Given this list of marker genes APPL1, CITED1, RBP4, GSTP1, CD2AP, KCNJ8, SRSF6, GSK3A, LPIN2, PAK1, PDK2, ECHDC3, CEACAM1, SOS1, KHK, SGCB, CAT, ZDHHC7, NCL, RPS6, PLN (phospholamban), IGF1R, AHSG, MEAK7, MYO1C, ERFE (NCBI Gene Id 151176), EIF6, IL1B, HRAS, MAPK3, WDTC1, PRKDC, PRLH, BCAR1, BGLAP, PIK3C2A, SOS2, FOXO1, INSIG1, GCK, ABCC8, KLF15, TNS2, POU4F2, PRKCI, SRD5A1, SLC25A33, INHBB, CPEB1, GRB14, SMARCC1, SNX5 (sorting nexin 5), LEP, NDEL1, ADIPOQ, PIK3R1, SLC27A1 (solute carrier family 27 member 1), RBX1, RELA, NR1H4, XBP1, KANK1, RAB8A, CRY2, PIK3R3, FER, SESN2, PKM, PDK4, ZNF592, RARRES2, CFLAR, FOXO4, SREBF1, HADH, SELENOS, SLC27A4, C2CD5, SIK2, TRARG1, OTC, PRKCB, MAPK14, GRB2, FABP3, OTOP1, PRKCZ, ATP2B1, SOCS1, SOCS3, RPS6KB2, YWHAG, GCNT1, STXBP4, LONP1, TRPV4, INSIG2, RAB31, CELA2A, FBP1, BCAR3, AP3S1, AKT2, USF1, ZNF106, PCSK9, SIRT1, MAPKAP1, SORL1, STXBP3, NPPA, PHIP, GPR21, CRY1, GPLD1, PTPN11, SORT1, SESN3, TBC1D4, EIF4EBP2, NUCKS1, UCP3, GSK3B, RAB13, IGF2, VAMP2, ZBED3, RAF1, EEF2K, SP7, PID1, KCNQ1, CTSD, PRKCD, GHRHR, TRIB3, HSD11B2, PIP4K2C, PLA2G1B, CAD, INS, RETN, GCLC, SORBS1, SRSF5, MIR195, ACVR1C, MIR15B, GHR, CSRP3, ADIPOR1, NAMPT, CUL3, UCP2, INPPL1, LYN, FFAR3, PRKAA1, MYO5A, GAL, NCOA1, MSTN, COL1A1, APC, MIR1271, IRS2, RHOQ, FBXW8, AGRP, CUL7, IDE, PCK1, SLC39A14, PNPLA3, SLC2A1, MAPK1, VGF, SLC2A4, PIK3R2, HADHA, EPRS1, TNFRSF11A, KBTBD2, SLC2A8, USO1, ALAS1, RB1, TRIM72, BAIAP2, ALPL, GHSR, SP1, ENPP1, IGFBP1, FUT7, TSC2, KAT2B, SLC22A12, RBM4, HDAC5, IGF1, EPM2AIP1 (NCBI Gene Id 9852), SHC1, PPARG, CAV2, MC4R, PTPRJ, CPEB2, GOT1, RAB10, TSC1, INPP5K, MIR107, PIP4K2A, PIK3CA, PKLR, IRS1, GKAP1, IL10, EGR1, PTPN1, C1QTNF12, MTCL2, OPRK1, AKT1, VPS13C, INSR, ERRFI1, GPR82 (NCBI Gene Id 27197), GALP, PPARA, MIR103A1, UPRT, RPS6KB1, SH2B2, NCK1, HMGCS2, FOS, HDAC9, VWA2, SLC9A1, GRB7 (growth factor receptor bound protein 7), SYAP1 (synapse associated protein 1), APPL2, INSRR, PDPK1, LPIN3, DENND4C, NCOA5, COL6A1 (NCBI Gene Id 1291), MIR379, SERPINA12, SOCS7, ZBTB7B, PRKCQ (NCBI Gene Id 5588), GAB1, MZB1 (NCBI Gene Id 51237), DNAI1, FOXC2, AANAT, IRS4, LPIN1, STAT1, PDE3B, OGT (O-linked N-acetylglucosamine (GlcNAc) transferase), PTPN2, PIP4K2B, CAPN10, SCAP, SRSF4, PARP1, PCK2, OSBPL8, G6PC1, NCOA2, ZFP36L1, GRB10, BLVRB, MTOR, PTPRE, here is a description of the gene set: studied in species Homo sapiens Any process that results in a change in state or activity of a cell or an organism (in terms of movement, secretion, enzyme production, gene expression, etc.) as a result of an insulin stimulus. Insulin is a polypeptide hormone produced by the islets of Langerhans of the pancreas in mammals, and by the homologous organs of other organisms. Human Gene Set: GOBP_RESPONSE_TO_INSULIN